Given this list of marker genes Fyn, Clec4d, Syk, Clec4n, Plcg2, here is a description of the gene set: This event has been computationally inferred from an event that has been demonstrated in another species.<p>The inference is based on the homology mapping from PANTHER. Briefly, reactions for which all involved PhysicalEntities (in input, output and catalyst) have a mapped orthologue/paralogue (for complexes at least 75% of components must have a mapping) are inferred to the other species. studied in species Mus musculus part of: C-type lectin receptors (CLRs) electronically inferred by orthology from the curated human pathway Reactome Pathway: Dectin-2 family